Given this list of marker genes BSCL2, PMPCA, SDHB, SDHD, PSAP, SDHAF1, HEXB, CYP27A1, ARSA, KCTD7, GLB1, GBA1, SDHA, here is a description of the gene set: species: Homo sapiens Human Gene Set: HP_PROGRESSIVE_PSYCHOMOTOR_DETERIORATION Progressive psychomotor deterioration